Given this list of marker genes ZBTB24, HMOX1, PNP, STAT1 (signal transducer and activator of transcription 1), ELANE, GSTM3, RNF31, ZNF341, SLC26A9, PIK3CD, STAT3, RAG2, MPEG1, PSMB10, TGFB1, SLC6A14, FOXN1, MIF, SLC11A1, CLCA4, IL17RC, TLR8, SERPINA1, DCTN4, JAK3, KCNN4, IL2RG, IL12RB1, NHP2, CFTR, SLC9A3, CYBB, CEACAM3, CARD11, MBL2, DCLRE1C, RAG1, RFXANK, EDNRA, IL7R, IRF1 (interferon regulatory factor 1), STX1A, HFE, IGHG2, C1QB, ZNFX1, GCLC, IKBKG, ZAP70, IGKC, CARD9, ADA, IL21R, CD40LG, PDCD1, CEACAM6, here is a description of the gene set: Opportunistic infection Human Gene Set: HP_OPPORTUNISTIC_INFECTION An infection that is caused by a pathogen that would generally not be able to cause an infection in a host with a normal immune system. Such pathogens take advantage of the opportunity, so to speak, that is provided by a weakened immune system. species: Homo sapiens